The following is a description of a gene set: studied in species Homo sapiens Any process involved in the activation of any of the steps of the alternative pathway of the complement cascade which allows for the direct killing of microbes and the regulation of other immune processes. Human Gene Set: GOBP_COMPLEMENT_ACTIVATION_ALTERNATIVE_PATHWAY, and this is the list of marker genes: CR2, VSIG4, C7, CFD, MIR520B, CFB, C3, C8B, CFH, SUSD4, CFP, MIR520E, C9, C5, CFHR5, C8A, CR1, C8G